Given this list of marker genes Dusp1, Ptgs2, Fosb, Btg2, Fos, Tsc22d3, Pmaip1, Junb, Egr1, Trib1, Pim1, Ddx5, Atf3, Zfp36, here is a description of the gene set: Genes negatively differentially expressed in cell type: cDC2 (conventional dendritic cell type 2) upon treatment with cytokine: EGF in mouse lymph nodes in vivo. Mouse Gene Set: CUI_CDC2_EGF_RESPONSE_DN from publication Cui A, Huang T, Li S, Ma A, Pérez JL, Sander C, Keskin DB, Wu CJ, Fraenkel E, Hacohen N (PMID 38057668) species: Mus musculus Cytokines mediate cell-cell communication in the immune system and represent important therapeutic targets. A myriad of studies have highlighted their central role in immune function, yet we lack a global view of the cellular responses of each immune cell type to each cytokine. To address this gap, the authors created the Immune Dictionary, a compendium of single-cell transcriptomic profiles of more than 17 immune cell types in response to each of 86 cytokines (>1,400 cytokine-cell type combinations) in mouse lymph nodes in vivo. A cytokine-centric view of the dictionary revealed that most cytokines induce highly cell-type-specific responses. For example, the inflammatory cytokine interleukin-1β induces distinct gene programmes in almost every cell type. A cell-type-centric view of the dictionary identified more than 66 cytokine-driven cellular polarization states across immune cell types, including previously uncharacterized states such as an interleukin-18-induced polyfunctional natural killer cell state.